The following is a description of a gene set: from publication Wherry EJ, Ha SJ, Kaech SM, Haining WN, Sarkar S, Kalia V, Subramaniam S, Blattman JN, Barber DL, Ahmed R (PMID 17950003) species: Homo sapiens Human Gene Set: GSE9650_EXHAUSTED_VS_MEMORY_CD8_TCELL_DN CD8 T cells normally differentiate from resting naïve T cells into function effector and then memory CD8 T cells following acute infections. During chronic viral infections, however, virus-specific CD8 T cells often become exhausted. We used microarrays to examine the gene expression differences between naive, effector, memory and exhausted virus-specific CD8 T cells following lymphocytic choriomeningitis virus infection. Genes down-regulated in comparison of exhausted CD8 T cells versus memory CD8 T cells., and this is the list of marker genes: CALU, PITPNC1, ANXA6, CHP1, OR2H2, IRF2BP1, IMPDH2, ANTKMT, DYM, PRPSAP1, IKBKE, AP3M1, NSG2, TSPAN31 (tetraspanin 31), FCGR2B, PLP2 (NCBI Gene Id 5355), OAZ1, ELAVL1, ADD1, STK38, PFKP, MRPL37 (NCBI Gene Id 51253), PSMD13, LEF1, CCT6A, TOB1, KCNJ8, TDRP, NGDN, ITGB2, RABGGTA, ASS1 (NCBI Gene Id 445), EEIG1, PIGX, SLC25A51, IFRD2, ITPA, IQGAP2, IL18R1, ITGB7, GPC1, TAF11, SNIP1, ENTPD4, VAV1, SLCO3A1, EYA2, IFITM10, UFC1, MAT2A, STK16, SGK1, SELL, CUX1, DNAJC7, PWP1, MBP, ACP5, LDHA (lactate dehydrogenase A), GNPAT, CCNDBP1, NHERF1, ARL6IP5, ANXA1, HPCAL1, IL7R, RNPS1, MOGS, XRCC5, HEXA (NCBI Gene Id 3073), SWI5, MAP1LC3B, CCND3, CCDC115, ITGAX, KLF6, PACS1, SNRNP40, PDK1, ICAM2, PIK3R1, HMCES, VPS25, EIF1, ARMC1, FAM107B, C8orf33, PRKCB, GALNT11, PIK3CD, KLRK1, ORC5, YES1, CLP1, DERL2, KLRC1, MRPL50, MACIR, BCL2, RERE, SAE1, TM9SF2, SEMA4A, EIF2S1, TAGLN2, TRAM1, IL18RAP, SPTLC1, LYSMD1, TTC7B, ATP6V1H, AURKAIP1, C18orf32, EXOSC7, NSMCE1, FARSB, ZFP36, COPS5, CCR2, ARL4C, FBL, RABAC1, APEX1, SELENOH, ELOVL5, SARAF (store-operated calcium entry associated regulatory factor), ANAPC5, ABLIM1, FAM89B, EBNA1BP2 (EBNA1 binding protein 2), CCT8, UBALD2, YIPF1, PLAC8, ETS1, BLVRA, API5, WDR13, RNASEH2A, ADRB2, LDAH, KCNN4, RHOA, ST8SIA1, ANAPC16, MIEN1, ADCY7 (NCBI Gene Id 113, adenylate cyclase 7), PIP4P2, KLRD1, NUDT16L1, TMEM222, USP24, ACSS1, TWF2, PIGU, GLO1, ITIH4, TUBB, IL6R, SUCLG1, NUDCD3, CCT4, RPN1, WDR43, SETD4 (SET domain containing 4), FAM117A, NDUFA9, SS18, CDC37, SRI, ANXA5, EIF3B, IL17RA, CD44, FOS, RREB1, KCTD10, GABARAPL2 (GABA type A receptor associated protein like 2), YIF1A, POLDIP2, SRPK1, TLE4, GOLM1, DUSP1, HADHB, ITGAL, KLK8, SMU1, GM2A, SATB1, DGKA, AXIN1, SACM1L, LARP1, GALNT10, PARK7 (Parkinsonism associated deglycase), BNIP3L, SLC1A5, SMARCA2, GRAMD2B